The following is a description of a gene set: Mouse Gene Set: GOBP_LIPID_OXIDATION The removal of one or more electrons from a lipid, with or without the concomitant removal of a proton or protons, by reaction with an electron-accepting substance, by addition of oxygen or by removal of hydrogen. species: Mus musculus, and this is the list of marker genes: Adh7, Nucb2, Adipoq, Klhl25, Sox9, Cpt1a, Pex13, Aloxe3, Hsd17b10, Apod, Ilvbl, Abcc9, Pdk4, Sirt4, Fmo2, Mfsd2a, Dgat2, Alox5, Acadm, Twist1, Acaa2, Cyp4v3, Ehhadh, Fabp1, Acat1, Mtln, Tysnd1 (trypsin domain containing 1), Adh4, Mir214, Acacb, Pla2g7, Irs2, Etfbkmt, Alox12b, Pparg, Fmo4, Acad11, Acad10, Acsbg2, Cpt2, Mtor, Scp2, Eci2, Blvra, Cygb, Acsl5, Sesn2, Echdc2, Acad12, Adh5, Acox1, Dbi, Adipor1, C1qtnf2, Cnr1, Obp2a, Samd1, Abcb11, Mir199a-2, Lonp2, Alox12, C1qtnf9, Hadhb, Ppargc1a (peroxisome proliferative activated receptor, gamma, coactivator 1 alpha), Abcd1, Akt2, Acaa1a, Pex7, Abcd3, Hacl1, Cpt1b, Ppara, Bdh2, Por, Irs1, Adipor2, Pex2, Acads, Ivd, Hao2, Etfdh, Crat, Prkaa1, Aldh1l2, Hadh, Etfb, Alox8, Phyh, Akt1 (thymoma viral proto-oncogene 1), Hadha, Slc25a17, Mapk14, Pex5, Acadvl, Cyp4f13, Slc27a2, Echs1, Mlycd, Acadl, Hao1, Etfa, Acaa1b, Abcd2, Gdf15, Eci1, Acox2, Cp, Eci3 (enoyl-Coenzyme A delta isomerase 3), Fmo1, Ech1, Echdc1, Alox15, Gcdh, Hsd17b4, Acoxl, Crot, Appl2, Dgat1, Auh, Abcd4, Ppard, Lep, Acox3, Alox12e, Decr1, Fabp3, Plin5 (NCBI Gene Id 66968)